The following is a description of a gene set: Human Gene Set: GOBP_CELLULAR_RESPONSE_TO_INTERLEUKIN_1 Any process that results in a change in state or activity of a cell (in terms of movement, secretion, enzyme production, gene expression, etc.) as a result of an interleukin-1 stimulus. studied in species Homo sapiens, and this is the list of marker genes: HES1, RORA, VRK2, ACOD1, INHBB, HIF1A, BMI1, NR1D1, CCL3, AKAP12, SIGIRR, CEBPB, ADAMTS12, IRAK1, NFKBIA, RBMX, DAB2IP, SOX9, TANK, EDN1, RPS6KA4, MYLK3, IL1RL2, CD47, IRAK3, CAMP, MIR21, IL1B, OTUD4, IRAK2, GBP2 (NCBI Gene Id 2634), TOLLIP, MAPK13, MIR146A, KMO, LCN2, CFL1, USP10, IRAK4, MIR27A, RC3H1, IL17A, TNIP2, HYAL3, NLRP7, FGB, MAPK3, YY1, PLCB1, EGR1, CACTIN, ZNF675, ZC3H12A, IL1RAP, PTGIS, GBP1, PYCARD, RELA, IL1RN, SIRPA, HAS2, UPF1, CD40, MMP2, ANKRD1, ZBP1, KLF2, CCL5, IKBKB, MAP3K7, TRAF6 (TNF receptor associated factor 6), MAP2K7, PYDC1, ST18, IL1R2, MYD88, NKX3-1, MAPK11 (NCBI Gene Id 5600), MIR766, HYAL2, GBP3, CCL2, RPS6KA5, TAX1BP1, SFRP1, IL6, ADAMTS7, CXCL8, IL1R1, HYAL1